Given this list of marker genes IKBKB, GJB2, NCSTN, PTPN6, MEFV, GJB6, KDF1, KRT5, PSENEN, POGLUT1, HYOU1, POFUT1, PSEN1, here is a description of the gene set: Acne inversa Human Gene Set: HP_ACNE_INVERSA A chronic skin condition involving the inflammation of the apocrine sweat glands, forming pimple-like bumps known as abscesses. studied in species Homo sapiens